Given this list of marker genes RBP4, HNRNPK, YAP1, TCTN2, INTS1 (NCBI Gene Id 392616), DPYSL5, SIX3, PIGL, SATB2, TGIF1, ERF (NCBI Gene Id 2077), ALG2 (NCBI Gene Id 85365), GLI2, ATP6V1A, ADNP, TBR1, RAB3GAP2, ACTB, LRP2, EIF3F, SPINT2, KDM6A, B3GALNT2, MAB21L2, NSD2, GAS1, C12orf57, FOXE3, TMEM231, DYRK1A, CHD7, TCTN1, CLDN19, MPDZ, PACS1, CAPN15, PORCN, ROR1, CRIPTO, CRYBB1, TMEM138, TBX4, SIN3A, SPATA7, CEP290, B9D2, POMGNT2, POLR1D, FKTN, CRYAA, CEP104, POMT2, PIBF1, FIBP, MBTPS2, FLNA, PRMT7 (protein arginine methyltransferase 7), PDE6D (NCBI Gene Id 5147), ZNF423, CRYGC, RPGRIP1L, NMNAT1, NODAL, TRRAP, MED12L, TOGARAM1, ASXL1, CRYBB2 (crystallin beta B2), CPLANE1, FGF3 (NCBI Gene Id 2248), CHN1, MMP14, TBC1D20, CC2D2A, KRAS (NCBI Gene Id 3845), FGFR1, KMT2D, CPLX1, ESCO2, KIAA0586, NIPBL, MKS1, MAF, BCOR, CRYBA4, INPP5E, MAN2C1, PNPLA6, PTCH2, TRIM37, NAA10, HHAT (NCBI Gene Id 55733), GMPPB, FOXH1, FGFR2, KIAA0753 (KIAA0753), NOTCH3 (NCBI Gene Id 791), ACTG1, TMEM216, NSUN2, MIR204, GDF6, VPS13B, BMP4, ELP4, NR4A2, POGZ, DLL1, MAFB, DHCR7, LRAT, VSX2, RPE65, GZF1, SMCHD1, IGBP1, POLR1B, PRR12, SUFU, ABCB6, COX7B, SRD5A3, AHI1, PIGG, KIF7, RAP1B, CRB1, IFT74, DHX38, RSPO2, MMACHC, WAC, ALG3, CRPPA, TRIM44, OFD1 (NCBI Gene Id 8481), B9D1, PUF60, NELFA, POMT1, RAB18, TBC1D23, CRYGD, DISP1, ARL3, LARGE1, COL4A1, SALL4, KATNIP, DAG1, HCCS, CCDC22 (NCBI Gene Id 28952), HRAS, PTCH1, WDR37, PXDN, PERCC1, ZNF668, RB1, IFT56, RERE, FLI1, VPS35L, B3GLCT, ALDH1A3, GDF3, CEP120, KCTD1, MMP2, ATOH7, ZIC2 (Zic family member 2), RXYLT1, SPTBN1, ALX3, GJA8 (NCBI Gene Id 2703), SMO, C2CD3 (C2 domain containing 3 centriole elongation regulator), RAB3GAP1, FOXC1, B4GAT1, AKT1, PAX2, PRPS1, SALL1, ARMC9, LETM1, FZD5, CDON, NRAS, NOTCH2, TMEM67, LIG4, TBX22, DPYD, OTX2, ANK1, KIFBP, CSPP1, FGFRL1, MITF, CEP41, TCEAL1, WASHC5 (NCBI Gene Id 9897), FKRP (NCBI Gene Id 79147), NPHP1, SALL2, SIX6, TMEM237, EP300, CTBP1, POLR1C, PQBP1, LCA5, DDX59, POMGNT1, SEMA3E, DACT1, HMGB3, SHH, TCTN3, WNT3, EPCAM, NDUFB11, ZMIZ1, HMX1, GNAQ, CBY1, CASK, POMK, HYLS1, FBXW11, PLVAP, MED13L, TENM3, PAX6, FGF8, TCOF1, SOX2, PCYT1A, TMEM218, CREBBP, ARL13B, SPECC1L, ZEB2, MAX, TFAP2A, ESAM, CENPF, DDX11, here is a description of the gene set: species: Homo sapiens Coloboma A developmental defect characterized by a cleft of some portion of the eye or ocular adnexa. Human Gene Set: HP_COLOBOMA